Given this list of marker genes Atp8b1, Atp11c, Atp11a, Atp8a2, Abca7, Abca1, Atp8a1, Atp8b3, here is a description of the gene set: studied in species Mus musculus Catalysis of the movement of phosphatidylserine from the cytosolic to the exoplasmic leaflet of a membrane, using energy from the hydrolysis of ATP. Mouse Gene Set: GOMF_PHOSPHATIDYLSERINE_FLOPPASE_ACTIVITY